Given this list of marker genes IYD, HGD, DCT, IL4I1, ACMSD, SLC45A2, KMO, TTC36, GSTZ1, GCDH (NCBI Gene Id 2639), OCA2, NADSYN1, PAH, IDO2 (NCBI Gene Id 169355), PCBD1, TYR (NCBI Gene Id 7299), ATP7A, FAH, QDPR, HAAO, TH, THAP4, AFMID, IDO1, TAT, HPD, KYNU, TDO2, here is a description of the gene set: Human Gene Set: GOBP_ERYTHROSE_4_PHOSPHATE_PHOSPHOENOLPYRUVATE_FAMILY_AMINO_ACID_METABOLIC_PROCESS studied in species Homo sapiens The chemical reactions and pathways involving erythrose 4-phosphate/phosphoenolpyruvate family amino acid.